Given this list of marker genes Itch, Il6ra, Scamp4, Lyplal1, Mpp2, Tom1, Pitpnc1, Nat8l, Gmfb, Dcx, Acsl4, Rfx3, Vdr, Cacna2d2, Vwa5b2, Zdhhc16, Casp2, Patz1, Eml5, Htr2c, Mmab, Gmnc, Slc4a7 (NCBI Gene Id 218756), Erp44, Plcb1, Snx15, Ucn2, Slc25a53, Trank1 (tetratricopeptide repeat and ankyrin repeat containing 1), Coro1c, Rtn4rl1, Calcb, Lgr4, Lhx2, Sirt1, Tmed8, 4930544G11Rik, Tnrc6b, Abr, Map2k1, Mdm4, Chd1, Zkscan16, Tanc2, Nav1 (NCBI Gene Id 408054), Hcn3, Pogz, Ppm1b, Ankrd52 (ankyrin repeat domain 52), E2f3, Foxj2, Pkp4, Synj1, Lman1, Nos1, Mta2, Ldha, Slc25a27, Nectin1, Pacs1 (phosphofurin acidic cluster sorting protein 1), Strn3, Pdgfra, Zfp644, Add2, Vcl, Ppp2r3a, Hexa, Numbl, Tbl1xr1, Dgkb, Scml2, Ttc19, Tbc1d2b, Mgat4a, Bnc2, Dpysl4, Celf3, Polq, Zfp282, Pip4p2, Wscd2, 9930012K11Rik, Hspb6, Met, Notch1, Car7, Atg4b, Lman2l, Tgif2, Nav3, Ahcyl2, Atp2b4, Slc6a1, Taf5, Osgin2, Ltbp2, Acsl1, Cntn2, Ccdc85a, Vat1, Azin2, Mycn, Tmem255a, Tmem79, Ago4, Rmnd5a, Dcaf7, Lef1, Srpra, Shkbp1, Frk, Nrip3, Rras, Arhgap26, Gpr165, Abcd1, Rtl4, Fut8, Camta1, Etl4, Mtcl2, Golph3l, Thumpd1, Foxn2, Dgkz, Notch2, Ppp1r11, Snx12, Mex3c, Ccne2, Cbfa2t3, Ppargc1b, Slc44a2, Kitl, Rhoh, Fbxo30, Akap6, Svop, Tppp, Ubl4a, Rps6ka4 (ribosomal protein S6 kinase, polypeptide 4), Pnoc, Ing5, Lzts3 (NCBI Gene Id 278961), Asic2, Zfp281, Tent5a, Calcr, Ergic1, Creb3l2, Brpf3, Arhgap1, Pip5k1a, Arid4b, Scn2b, Kcna6, Krtap16-1, Tmem45a2, Erc1, Rragc, Zmym4, Fam107a, Cuedc1, E2f5, Satb2, Jade2, Fam83h, Mmp25, Syt1, Gabra3, Unc13c, Galnt7, Serpinf2, Mllt3, Slc4a8, Tmem164, Dixdc1, Sidt2, Usf1, Gpr158, Metap1, Daam1, Thtpa, Gpr22, Rab21, Fam76a, Kti12, Vamp2, Fut9, Zfp120, Csf1r, Ddx17, Ppfia1, here is a description of the gene set: species: Mus musculus Genes predicted to be targets of miRBase v22 microRNA mmu_miR_34c_5p in miRDB v6.0 with MirTarget v4 prediction scores > 80 (high confidence targets). Mouse Gene Set: MIR_34C_5P from publication Chen Y, Wang X (PMID 31504780)